The following is a description of a gene set: The chemical reactions and pathways resulting in the breakdown of a polysaccharide, a polymer of many (typically more than 10) monosaccharide residues linked glycosidically. Mouse Gene Set: GOBP_POLYSACCHARIDE_CATABOLIC_PROCESS species: Mus musculus, and this is the list of marker genes: Ins1, Chil3, Ppp1r3d, Wdr45b, Atg2b (autophagy related 2B), G6pc1, Gabarapl1, Ppp1cb, Wdr45, Agl, Phkg1, Atg2a, Pygl, Atg12, Adrb1, Ppp1r3b, Gaa, Stbd1, Wipi1, Pygb, Ppp1r3c, Mgam, Adra1b, Hmgb1 (high mobility group box 1), Ins2, Phkg2, Rb1cc1, Ppp1r3e, Pgm1, Phka1, Pgm2, Chit1, Chia1, Wipi2, Adcy10, Pygm, Phkb, Atg3, Ppp1ca, Pfkm